The following is a description of a gene set: Genes down-regulated in comparison of naive CD8 T cells versus effector CD8 T cells KLRG1 high. Human Gene Set: GSE10239_NAIVE_VS_KLRG1HIGH_EFF_CD8_TCELL_DN species: Homo sapiens Using killer cell lectin-like receptor G1 as a marker to distinguish terminal effector cells from memory precursors, we found that despite their diverse cell fates both subsets possessed remarkably similar gene expression profiles and functioned as equally potent killer cells. However, only the memory precursors were capable of making IL-2 thus defining a novel effector cell that was cytotoxic, expressed granzyme B, and produced inflammatory cytokines in addition to IL-2. This effector population then differentiated into long-lived protective memory T cells capable of self-renewal and rapid re-call responses. Mechanistic studies showed that cells that continued to receive antigenic stimulation during the later stages of infection were more likely to become terminal effectors. Importantly, curtailing antigenic stimulation towards the tail-end of the acute infection enhanced the generation of memory cells. These studies support the decreasing potential model of memory differentiation and show that the duration of antigenic stimulation is a critical regulator of memory formation from publication Sarkar S, Kalia V, Haining WN, Konieczny BT, Subramaniam S, Ahmed R (PMID 18316415), and this is the list of marker genes: SGCB (sarcoglycan beta), HASPIN, NDUFAF6, TMEM163, TSPAN33, SYCE2, PDGFA, NCAPD2, RAD51AP1, CMSS1, HMMR, TMCO1, TRIM37, PLIN2, RPS19BP1, MRPL35, GAS2L3, AKIP1, DUSP14, NEIL3, ENDOD1, SDCBP2, CKS1B, AURKB, CYFIP1, MINDY3, PKD2, MCM4, STMN1, FHL1, PIF1, HIRIP3, PDK3, UCHL3, CDKN1A, PRDM1, TACC3, CAPN2, GSTT1, SAR1B, DTYMK, SLC7A10, TTK, ZFAND4, SLC1A4, CDCA8, TEX30, NEK2, CIP2A, RFWD3, MED18, HK2, RAB34, LGALS3, KPNA2, RILPL2, SDF2L1, RFC5, PMVK, CHEK1 (NCBI Gene Id 1111), CKAP2, S100A4, GRIA2, FRMD4B, CDC20, BARD1, ASS1, GNPDA1, ARHGAP19, ASRGL1 (asparaginase and isoaspartyl peptidase 1), MAPRE2, CYP51A1, MTUS1, POU4F1, FLNB, MCM5, MT2A, PRC1, PRDX4, PBK, COQ7, ITGA4, EME1, OSBPL3, CXCL14, GEM, PSMD13, CMC2, LSS, ETFB, CASP7, XBP1, ACTL6A, SKIC8, E2F8, ZNHIT3, CDCA5, GMDS, RPH3AL, KIF4A, HMBS, ZCCHC4, SNRNP40 (NCBI Gene Id 9410), TMEM165, SPAG5, MARCHF10, ALAD, MBNL3, DIO2 (NCBI Gene Id 1734), ZGRF1, HLA-A, TK1, RNF216, C7orf50, UBASH3B, GLDC, STX11, MANF, IKZF3, SAP30, PTCHD1, NSMCE2, CA12, SNX10, DCTPP1, NUP37, SELENOI, RANBP1, SNRPD3, PIK3AP1, RAD51C, USP14, ARL6, NRP2, SPATS2L, TYMS, MRPS10, MRPL15, ZNF503, TOX2, ZWILCH, DERA, CCDC34, FKBP1A, NR1H4, PTPN3, NDUFS3 (NCBI Gene Id 4722), DIP2A, NDE1, GINS2, GLRX2, ERCC6L, MTFR2, ANLN, TIAM1, ATP5IF1, MYO5A, MICAL2, KIF22, RAD54L, MAD2L1, BRCA2, DUSP4, E2F7, TNFRSF1B, IRF8, FARP1, LRP8, SLC25A33, PGRMC1, NAA20, ANXA2, PDSS1, TIPIN, SCUBE3 (NCBI Gene Id 222663), LRR1, CCR5, PLSCR1, PIGF, SLC22A15, INCENP, KNTC1, EPAS1, SPDL1, CCNE1, AP3S1, MAGOHB, SLC43A3, SLAMF7 (SLAM family member 7), DUSP19, CENPH, ELL2, PALS2, FIRRM, CFAP95, NDUFAF5, PI4K2B, MELK, ALG8, NME1